The following is a description of a gene set: studied in species Homo sapiens HIV Transcription Initiation Human Gene Set: REACTOME_HIV_TRANSCRIPTION_INITIATION, and this is the list of marker genes: POLR2A, TAF6, GTF2H2, TAF9B, POLR2J, ERCC3, TAF10, CDK7, TAF4B, POLR2H, TAF7L, GTF2A2, GTF2H4, TBP, GTF2E2, GTF2H1, CCNH, TAF1L, POLR2C (NCBI Gene Id 5432), GTF2B, POLR2E, POLR2F, GTF2A1, GTF2H3, TAF2, TAF15, POLR2G, GTF2H5, TAF12, TAF4, TAF13, TAF11, POLR2L, ERCC2, POLR2I, TAF1, GTF2F1, POLR2D, TAF9, POLR2K, GTF2E1, POLR2B, TAF3, TAF5, GTF2F2, MNAT1, TAF7